The following is a description of a gene set: Human Gene Set: HE_LIM_SUN_FETAL_LUNG_C1_GHRL_POS_NE_PRECURSOR_CELL from publication He P, Lim K, Sun D, Pett JP, Jeng Q, Polanski K, Dong Z, Bolt L, Richardson L, Mamanova L, Dabrowska M, Wilbrey-Clark A, Madissoon E, Tuong ZK, Dann E, Suo C, Goh I, Yoshida M, Nikolić MZ, Janes SM, He X, Barker RA, Teichmann SA, Marioni JC, Meyer KB, Rawlins EL (PMID 36493756) GHRL+ NE precursor species: Homo sapiens, and this is the list of marker genes: LCMT2, DNAJC5, CADPS, MVB12B, QSOX2, SPTBN2, GIPR, ICA1L, MIR7-3HG, NPIPB4 (nuclear pore complex interacting protein family member B4), BEND7, PCLO, SOBP, TMEM178A, ZDHHC14, NRCAM, TMEM65, CFC1, VSTM2L, DOP1B (DOP1 leucine zipper like protein B), PTPRN, ADGRG1, NLRP1, RIPPLY3, SLC7A5, FAM131A, STON2, TTC39A, CEP126, TCEAL2, IRS1, TTLL7, UNC80, TMEM51, SYT7 (NCBI Gene Id 9066), DLL3, TTR, WNK2, GRP, NACAD, FBXO6, BACE1, PCSK2, ARFGEF3, PKD1, MAB21L4, SPIRE2, SRRM4, NRG1, JAM3, MMRN1 (NCBI Gene Id 22915), PROX1, RTN1, DDC, RASA4, AKT3, ARHGAP32, PCDH17, PLCXD2, DUSP18, PLPPR2, TRAM2, ARHGEF11, NOL4 (NCBI Gene Id 8715), GPR160, SCGN, SHISAL2B, LSS, SLC29A4, INSM1, ZBTB18, ENO2, TSPAN7, LRFN4, CELF3 (NCBI Gene Id 11189), COL12A1, SSTR2, LZTS3, CDH10, SPECC1, CRMP1, RGS11, SRGAP3, GDAP1, MATN2, TBL1X, GLYCTK, RPRM, CYTH3, FLVCR1, RCOR2, CHGB, RIMKLA, RIC3 (RIC3 acetylcholine receptor chaperone), STXBP1, GNG2, GPBAR1, AAK1 (AP2 associated kinase 1), SYNJ2BP, PRXL2C, LRRC24, SEZ6L2, IGFBP3, PRDM16-DT, CAMK1D, LINC01574, CBFA2T3, APLP1, PGAM2, ITGB8, MAMLD1, MICAL3, RGS4, AP1AR, SYP, TRNP1, FAM222A, ZNF646, SPTSSB, RGS17, NT5DC3, LINGO1, POU2F2, TCEAL5, DIRAS2, NLGN1, PFKP, STX2, CACNA2D1, PDE2A, PAPSS2, QPCT, ROBO2, AMPH, ZFHX2, SV2A (NCBI Gene Id 9900), KLHL32, BIK (NCBI Gene Id 638), GRK3, NAAA, MS4A8, ASCL1, RBM11, GAL3ST1, RUNX1T1, NRXN1, RGS7, ZDHHC8, SLC4A3, PLXNC1, ANK2, NEURL1, HES6, KLF16 (KLF transcription factor 16), MAP7D3, SLCO3A1, VSTM2A, KCNN3, SYT11, CHGA, STMN3, MAPK15 (NCBI Gene Id 225689), CD200, CENPS, NSMF, KLF12, CDKN2D, GPX3, SPR, CACNG4, HORMAD2-AS1, ANKH, LY6H, SLC6A8, KCNH2, CRYM, SRGAP1, CNIH2, SNAP25, NCALD, SYT13, ST6GALNAC5, ABCC8, ORAI2, PTPRN2, EYA4, MARK1, STX1A, ARHGEF4, STK32A, THSD4, ARHGEF26, GPATCH11 (G-patch domain containing 11), NPIPA5, NAV1, RCN3, HEPACAM2, FBXO44, TMED8, PPP6R1, VWA5B2, DLG5, KLHL3, RFX6, NUMBL, CDHR3, GALNS, HIRA, LINC00261 (NCBI Gene Id 140828), NPIPA1, MAP6, CLIP3, BCORL1, TP53INP1, DLL4, CXXC4 (NCBI Gene Id 80319), TOM1L2, RAB26, FGF14, MSI1, PROC, C21orf58, CNNM1, MAST1, JRK, MAP4K2, PARD6A, STMN2, HSD11B1L, TCEAL7, PRKCE, CACNB2, INHBA, C14orf132, PDE8B, RAB3B, FAM110B, NUAK1, GIT1, RPS21-DT, DCHS1, RASA4B, PSD, ADGRL1, NKX2-2, CFC1B, ARHGEF10L, EXTL3, ADCY2, RALGDS, JAKMIP2, RAPGEF4, KCNJ11, TOX, MAP1B, FAM171A1, NEUROD1, MAPK8IP1, DST, TAGLN3, ACTL6B, MAMDC4, PPP1R1A, TEX2, TNFRSF21, CLN8, DPP10, MAPRE3, NSG2, SCG5, DPYSL3, SYNJ2, DEF8, MMP25-AS1 (NCBI Gene Id 124900372), APPAT, SERP2, KIF1A, MAP2, FAM215B, GOLGA6L9, DDN-AS1, MAPKBP1, PCSK1, CNTNAP2, LRP11, CTXN1, ELAPOR1, OPTN, ABCA2, MCF2L (MCF.2 cell line derived transforming sequence like), RAP1GAP2, CDCP1, MGAT3, ABCA5, KAT2B, NCAM1, FSTL5, LINC01315, KL, TMEFF1, DEPP1, USP27X, SDC3, NAP1L5, CA8, TNFRSF25, CALY, AGBL4, PNMA2, DNAJC12, TTC9, RFX2, PALM, MFSD6, WASF1, TBC1D24 (TBC1 domain family member 24), TRAF3, NDRG4, SCRN1, LINC00342, BEX1, SMIM6, ARX, ATP2A3, DOCK11, CNTN1, ZNF793-AS1, GABRB3, SCAMP5, KCNMB2, DACH2, DGKZ, TUBB3, IQSEC1, DRAIC, ELAVL4, DUSP26, MTMR7, ASCL2, CLDN5, VPS33A, TRIM3, SEMA3A, REEP2 (receptor accessory protein 2), PPIP5K1, ITPR1, PLEKHH1, BEX5 (brain expressed X-linked 5), GPRIN3, FUT9, EMB, SDK1, PPFIA3, TESK1, RIMBP2, KCNJ6, GNAO1, ZFTA, NPDC1, SYT5, HIC2 (HIC ZBTB transcriptional repressor 2), ACSL1, CERS6, SLC38A11, DCX, CAMK2B, FOXA3, RUNDC3A, LYSMD2, HTR2C, THBS3, SCN3A, CIDEB, NBEA, FAM227A, CASZ1, DUSP4, A4GALT, INSR, NLRP2, VGF, TPST2, DACH1, SAP30L, KCNH6, GPC6, KLC2, FFAR4, CACNA1A, SCG3, PRADC1 (protease associated domain containing 1), BAIAP3, BTBD17, ACAP3, TMEM198, EFCAB11, SLC12A5, LIN7B, TUT1, KIF19, CENPF, USP41P, GCH1, CCDC28B, SMOC1, GHRL, EPHA4, SGPL1, MADD, SCG2, CAPN15, LARP6, MEGF9, PPP2R5B, CCSAP, C15orf48, SNCA, ST8SIA3, RHOU, RASD1, ABLIM2 (NCBI Gene Id 84448), BAHD1, CACNA1H, ACOT7, GRIK5, LYST, RIMS2, ISL1, RTL5